The following is a description of a gene set: Mouse Gene Set: GOBP_REGULATION_OF_CALCIUM_ION_TRANSPORT_INTO_CYTOSOL Any process that modulates the rate of the directed movement of calcium ions into the cytosol of a cell. The cytosol is that part of the cytoplasm that does not contain membranous or particulate subcellular components. species: Mus musculus, and this is the list of marker genes: Grin1, Cav1, Adcyap1r1, P2rx7, Bcl2, P2rx4, Bmp4, Ffar1, Bax, Trpc3, Asph, Cd4, Tmbim6, Lhcgr (NCBI Gene Id 16868), Oga, Akap5, Gimap3, Epo, Bak1, Gimap5, Pml